The following is a description of a gene set: Mouse Gene Set: GOBP_POSITIVE_REGULATION_OF_PHOSPHATIDYLINOSITOL_3_KINASE_PROTEIN_KINASE_B_SIGNAL_TRANSDUCTION Any process that activates or increases the frequency, rate or extent of phosphatidylinositol 3-kinase/protein kinase B signal transduction. species: Mus musculus, and this is the list of marker genes: Hcst, Pdgfd, Pik3ca, Arrb2, Src, Itgb1bp1, Igf1, Grm2, Tpbg, Nox4, Ccl19-ps4, Fermt2, Kdr, Cass4, Gata3, Ntrk2, Iapp, F2r, Spry2, Ngfr, Hbegf, Itsn1, Ret, Hcls1, Hpse, Fshr, Cx3cr1, Vav1, Ptpn6, Nrg1, Irs3, Ptprj, Mup5, Rtn4, Angpt1, Adora3, Csf1r, Park7, Mtdh, Plxnb1, Vegfa (NCBI Gene Id 22339), Fn1, Mup11, Ntrk1, Reln, Mup2, Rac1, Irs1, Maz, Arfgef1, Ccl19-ps5, Fgfr3, Ccl5, Ccl21a, Pld2, Ccl21e, Ins1, Csf3, Mydgf, Il18, Ccl19, Hgf, Ramp3, Il6, Cd28, F2rl1, Ddr2, Ambra1, Extl3, Akr1c18, Specc1l, Stk3, Ccl19-ps1, Bag4, Lep, Mtor, Ccl19-ps3, Calcr (calcitonin receptor), Osm, Chi3l1, Mst1r, Nedd4, Fyn, Sema3e, Stox1, Pdgfb, Fgf2, Tcf7l2, Phlpp1, Mfhas1, Tyro3, Prkd1, Epha8, Fer, Agap2, Cx3cl1, Phb1, Pdgfa, Nkx3-1, F2, Rasd2, Thpo, Tgfb2, Vegfb, Tnfsf11, Pdgfra, Ilk, Mup1, Klk1b4, Meis3, Jak2, Mertk (NCBI Gene Id 17289), Cpne1, P2ry12, Ube3a, Erbb4, Btbd10, Ptk2b, Ngf, Tgfbr1, Ccl21d, Erbb2, Igfbp5, Prr5, Myorg, Vav2, Egf, Mup3, P2rx4, Sema5a, Nts, C1qtnf12, Igf1r, Cd19, Ryk, Pros1, Agt, Fam110c, C1qbp, Tnf, Tmem100, Gas6, Pdgfc, Erfe, Flt1 (FMS-like tyrosine kinase 1), Gfral, Ndp, Egfr, Cat, Ltk (leukocyte tyrosine kinase), Tgfb1, Pik3cg, Xbp1, Axl, Gper1, Ppard, C1qtnf3, Wnt16, Fgr, Vav3, Sesn2, Nrxn1, Itgb1, Pik3ap1, Rictor, Dcn, Prr5l, Prkca, Unc5b, Tek, Lin28a, Trem2, Selp, Pdgfrb, Fgfr1, Thbs1, Igf2, Insr, Gdf15, Ntrk3, Serpina12, Sema4d, Mir205, Txn1, Adam8 (NCBI Gene Id 11501), Ins2, Ccdc88a, Hax1, Tspyl5, Ddr1, Ccl19-ps6, Pdpk1, Cntf, Cdc42, Mup4, Ccl21b, Mir494, Pik3r5, Sirt1, Osbpl8, Gpx1, Cxcl12, C1qtnf1, Hnf1a, Eng, Irs2, Myoc, Gcnt2, Ccl21f, Ptk2, Rgl2, Cbl